Given this list of marker genes Ewsr1, Ifi204, Ap2b1, Lilrb4a, Fyn, Diaph1, Tgfbi, Fabp5, Morf4l2, Sdc3, Trim30a, Gramd4, Pdia6, Pfn1, Efhd2, Dennd4b, here is a description of the gene set: from publication Cui A, Huang T, Li S, Ma A, Pérez JL, Sander C, Keskin DB, Wu CJ, Fraenkel E, Hacohen N (PMID 38057668) Mouse Gene Set: CUI_CDC2_IL5_RESPONSE_UP studied in species Mus musculus Genes positively differentially expressed in cell type: cDC2 (conventional dendritic cell type 2) upon treatment with cytokine: IL-5 in mouse lymph nodes in vivo. Cytokines mediate cell-cell communication in the immune system and represent important therapeutic targets. A myriad of studies have highlighted their central role in immune function, yet we lack a global view of the cellular responses of each immune cell type to each cytokine. To address this gap, the authors created the Immune Dictionary, a compendium of single-cell transcriptomic profiles of more than 17 immune cell types in response to each of 86 cytokines (>1,400 cytokine-cell type combinations) in mouse lymph nodes in vivo. A cytokine-centric view of the dictionary revealed that most cytokines induce highly cell-type-specific responses. For example, the inflammatory cytokine interleukin-1β induces distinct gene programmes in almost every cell type. A cell-type-centric view of the dictionary identified more than 66 cytokine-driven cellular polarization states across immune cell types, including previously uncharacterized states such as an interleukin-18-induced polyfunctional natural killer cell state.